The following is a description of a gene set: Any process involved in the carrying out of an immune response by a neutrophil. Human Gene Set: GOBP_NEUTROPHIL_MEDIATED_IMMUNITY species: Homo sapiens, and this is the list of marker genes: FCAR, NLRP6, ITGB2, SCNN1B, VAMP7, WDR1, STXBP2, ADAM17, MYD88, KMT2E, CARD9, STXBP3, DNASE1L3, CTSG, VAMP8, CD177, TREM1, F2RL1, DAO, PRAM1, VAMP2, JAGN1 (jagunal homolog 1), ELANE, ANXA3, ITGAM, SYK, ACE, BCR (NCBI Gene Id 729775), IL6R, PLA2G1B, TUSC2, ARG1, POMC, IRAK4, SPI1, CXCL6, AZU1, DNASE1, NCF1, IL6, PCYOX1L, F2 (coagulation factor II)